The following is a description of a gene set: Genes up-regulated during skin tumor progression from low risk papilloma vs normal skin. Mouse Gene Set: DARWICHE_PAPILLOMA_RISK_LOW_UP Chemical induction of squamous tumors in the mouse skin induces multiple benign papillomas: high-frequency terminally benign low-risk papillomas and low-frequency high-risk papillomas, the putative precursor lesions to squamous cell carcinoma (SCC). We have compared the gene expression profile of twenty different early low- and high-risk papillomas with normal skin and SCC. Unsupervised clustering of 514 differentially expressed genes (P<0.001) showed that 9/10 high-risk papillomas clustered with SCC, while 1/10 clustered with low-risk papillomas, and this correlated with keratin markers of tumor progression. Prediction analysis for microarrays (PAM) identified genes that distinguished the two papilloma classes, and a majority of these had a similar expression pattern in both high-risk papillomas and SCC. Additional classifier algorithms generated a gene list that correctly classified unknown benign tumors as low- or high-risk concordant with promotion protocol and keratin profiling. Reduced expression of immune function genes characterized the high-risk papillomas and SCC. Immunohistochemistry confirmed reduced T-cell number in high-risk papillomas, suggesting that reduced adaptive immunity defines papillomas that progress to SCC. These results demonstrate that murine premalignant lesions can be segregated into subgroups by gene expression patterns that correlate with risk for malignant conversion, and suggest a paradigm for generating diagnostic biomarkers for human premalignant lesions with unknown individual risk for malignant conversion. from publication Darwiche N, Ryscavage A, Perez-Lorenzo R, Wright L, Bae DS, Hennings H, Yuspa SH, Glick AB (PMID 17525749) studied in species Mus musculus, and this is the list of marker genes: Or8b12i, Sprr2i, Lypd2 (Ly6/Plaur domain containing 2), Il1b, 4930529K09Rik, Lhx3, Lmod2, Nhp2, Nfe2l2, Pdxdc1, Ppic, Bbln, Saraf, Ncl, Gabarapl2, Rbm12, Calm4, Ftl1, Gdf5, Cenpc1, Fam162a, Car3 (NCBI Gene Id 99954), Rab5if, Pds5b, Actl6b, Stfa1, Calcoco1, Rnase2b, Gba1, Tgfa, H2-M9, Ube2c, Hbb-y, Ldha, Qdpr, Ide, Sar1a, Cmpk2, Tcte1, Inava, Pgam1, Hrc, Fabp4, Hmbox1, Sprr2h, Dynlt2b, Slc35b1, 4930556N13Rik, Sprr2k, Trp73, Prg3, Prrc1 (proline-rich coiled-coil 1), Acot10, Tmem65, Eif5a, Tcp1, S100a11, Drd5 (NCBI Gene Id 13492), Lrif1, Enah, Chst11, Chi3l1, Hexa, Sfn, Col20a1 (collagen, type XX, alpha 1), Cacybp, Kprp, Nek4, Map6, Spic, Lif, Klk6 (kallikrein related-peptidase 6), Pfkl, Id1, Sprr2f, Fes, Chka, Armc9, Hbs1l, Jag1, Cacna1e (NCBI Gene Id 269133), Tuba8, Spns3, Trpc6, Spc24, Psg23, Akr1c18, Bhlhe22, Mcam, Stx16, Tmem248, Rpl39, Ryr1, Snhg9, Lce3b, Ltb4r1, S100a8, Trbv5 (NCBI Gene Id 21582), Snhg3, 4930547E14Rik, Slpi (NCBI Gene Id 20568), Plekha4, H2az1, Serpinb3c, Hamp, Rhoh, Mrpl19, Chpt1, Scn1b, Wdr70, Wfdc2, Vps37a, Pmepa1, Acad9, Rps6ka4, Atp6v0d1, Lgals2, Camk4, Siglece, Esd, Galk1, Ly6e, Hspd1, Sprr2g, Acan, Suclg2, Ifitm3, Eng, Art5, Il36a, Krtap6-5, Srm, Eef1d, Gclm, App, Ccdc38, Prss3b, 1110038B12Rik, Traf2, Lrrc58, Axl, Bzw1, Cx3cl1, Ywhab, Spag5, Cox19, Gpr15lg, Arg1, Sfpq, Pdcd5, Sprr2b, Cox5b, Txn1 (thioredoxin 1), Il17a, Pgk1, 1700105P06Rik, Homer3, Dynll1, Eef1b2, 2900064F13Rik, Mgat1, Aff3, Selenot, Eno1, Ptprcap, Ssu72, Sdr9c7, Capn2, Smim11, Rps3a1, Gsta1, Tnfrsf25, Rubcn, Uck2, Psg28, Klk9, Ext2, Elavl1, Ugt2b37, Srsf1, 6330403K07Rik, S100a9, Ftl2-ps, Rptn